The following is a description of a gene set: Primary hypothyroidism Human Gene Set: HP_PRIMARY_HYPOTHYROIDISM studied in species Homo sapiens A type of hypothyroidism that results from a defect in the thyroid gland., and this is the list of marker genes: ALMS1, DDOST, UBR1, CTNS, STAT1